The following is a description of a gene set: part of: Cap-dependent Translation Initiation Binding of the methionyl-tRNA initiator to the active eIF2:GTP complex results in the formation of the ternary complex. Subsequently, this Met-tRNAi:eIF2:GTP (ternary) complex binds to the complex formed by the 40S subunit, eIF3 and eIF1A, to form the 43S complex. Reactome Pathway: Formation of the ternary complex, and subsequently, the 43S complex species: Homo sapiens, and this is the list of marker genes: RPS8, EIF3H, 18S rRNA, RPS16, FAU (FAU ubiquitin like and ribosomal protein S30 fusion), EIF3M, EIF2S1, EIF3J, EIF3C, EIF3F, RPSA, RPS12, RPS21, RPS4Y1, RPS17 (NCBI Gene Id 6218), RPS3A, EIF3I, RPS2, RPS9, RPS24, RPS19, RPS15A, RPS10, EIF1AX, RPS14, EIF3B, RPS18, EIF3D, RPS13 (ribosomal protein S13), RPS28 (ribosomal protein S28), RPS6, EIF3K, EIF3G (NCBI Gene Id 9606), RPS27A, RPS29, RPS23, RPS3, RPS4Y2, EIF3E, EIF3A, RPS25, EIF2S2 (NCBI Gene Id 9359), EIF3L, RPS7, RPS20 (ribosomal protein S20), RPS26, RPS4X, RPS15, EIF2S3 (NCBI Gene Id 8422), RPS27L, RPS27, RPS11, RPS5